Given this list of marker genes Zdhhc9, Xpo1, Rps27a, Psmc3, Phb1, Fgfr1, Psmc1, Ppp2r5d (NCBI Gene Id 21770), Ubb, Psma2 (NCBI Gene Id 19166), Fgf1, Il2rb, Rapgef2, Hgf, Epgn, Lypla1, Cnksr2, Il5ra, Fgf22, Map2k1, Fyn, Lat, Csk, Btc, Pebp1, Irs2, Dlg3 (discs large MAGUK scaffold protein 3), Psmc2, Pea15a (proliferation and apoptosis adaptor protein 15A), Tyk2, Ncam1, Flt3l, Fgg, Rasgrp1, Prkaca, Wdr83, Ptk2, Psmd12, Rasa4, Ptpra, Fgf6, Psmb6 (proteasome (prosome, macropain) subunit, beta type 6), Mapk12, Ranbp9, Ret, Klb, Nrg3, Kl, Nrtn, Fgf10, Il6, Pak3, Ppp5c, Grin1, Fgf23, Artn, Psmc4, Fgf16, Il2, Psmb7, Jak3, Ppp2r5b, Spred3, Shc2, Psmc6, Ppp2r5a, Shc3, Mapk3, Shc1, Psmc5, Ksr2, Grin2d, Rasgrp3, Dusp2 (dual specificity phosphatase 2), Shoc2, Calm1, Dusp7 (dual specificity phosphatase 7), Psma5, Il6ra, Psmd6 (proteasome (prosome, macropain) 26S subunit, non-ATPase, 6), Mapk4, Psmd13 (NCBI Gene Id 23997), Prkacb, Rgl3, Itga2b, Psmd1, Hras, Hspb1 (NCBI Gene Id 15507), Csf2rb, Gdnf, Psmb4, Mapkapk5, Kit, Dusp16, Kitl, Csf2, Pik3cb, Psma6, Egfr, Camk2b, Dusp9, Il2ra, Il5, Ptpn7, Fgf2, Fgf5, Sptbn2 (NCBI Gene Id 20743), Frs2, Gfra2, Grb2, Ppp2r1b, Ptpn3, Il2rg, Psma3, Rasgef1a, Irs1, Psma1, Tln1, Rasa1, Tgfa, Psmb5 (proteasome (prosome, macropain) subunit, beta type 5), Areg, Gfra1 (NCBI Gene Id 14585), Brap, Ralgds, Fgf17, Dnajb1, Grin2b, Cnksr1, Dlg4, Dusp6, Pdgfa, Map2k2, Nefl, Psmd7, Psma4 (NCBI Gene Id 26441), Bcl2l1, Cdk1, Apbb1ip, Il3, Rasgrp4, Septin7, Rasal1, Erbb4, Pik3r2, Fnta, Sptbn4, Fgf15, Pdgfrb, Fgf4, Cdc42, Pdgfb, Fgf20, Lamtor2, Abhd17c, Dusp5, Fgf8, Psma7, Fgf7 (NCBI Gene Id 14178), Erbb2, Cdc14a, Arrb2, Rgl1, Rasal3, here is a description of the gene set: Reactome Pathway: MAPK family signaling cascades electronically inferred by orthology from the curated human pathway part of: Signal Transduction species: Mus musculus This event has been computationally inferred from an event that has been demonstrated in another species.<p>The inference is based on the homology mapping from PANTHER. Briefly, reactions for which all involved PhysicalEntities (in input, output and catalyst) have a mapped orthologue/paralogue (for complexes at least 75% of components must have a mapping) are inferred to the other species.